Given this list of marker genes UBB, DLL4, MIB2, ADAM10, RPS27A, UBC (ubiquitin C), NEURL1B, NOTCH1, NEURL1, JAG1, UBA52, ADAM17, DLL1, MIB1 (NCBI Gene Id 57534), JAG2, here is a description of the gene set: NOTCH1 heterodimerization domain mutations are frequently found in T-cell acute lymphoblastic leukemia (T-ALL) and result in constitutive activity of NOTCH1 mutants. part of: Signaling by NOTCH1 in Cancer Reactome Pathway: Signaling by NOTCH1 HD Domain Mutants in Cancer species: Homo sapiens